The following is a description of a gene set: Abnormally curly or curved eyelashes. Curly eyelashes studied in species Homo sapiens Human Gene Set: HP_CURLY_EYELASHES, and this is the list of marker genes: DVL1, SMC1A, WNT5A, SMC3, TAF6, SMARCA2, NIPBL, HDAC8, KCNJ8, ST14, ABCC9, DVL3, FZD2, STAG2, RAD21, BRD4